The following is a description of a gene set: Abnormality of the curvature of the cornea studied in species Homo sapiens Human Gene Set: HP_ABNORMALITY_OF_THE_CURVATURE_OF_THE_CORNEA, and this is the list of marker genes: BAP1, BRIP1, MYT1L, COL9A1, SDCCAG8, SLC4A11 (solute carrier family 4 member 11), BEST1, YY1, FANCC, RNF113A, FANCF, LZTFL1, KERA, LRAT, DSE, BBS10, AGBL5, SLC39A8, POGZ, UBE2T, SLC7A14, ZBTB7A, KCNV2, ARCN1, SNRNP200, ARID1B, CAPRIN1, GATAD2B, PALB2, AHI1, COL9A3, RD3, FANCM, GRHL2, SCAPER, EIF4H, NIPBL, DYRK1A, GDF6 (growth differentiation factor 6), RP1 (NCBI Gene Id 6101), TEAD1, CNGA3, KIF11, METTL27, AARS1, BRCA2, CCDC28B, BBIP1, MAD2L2, GTF2H5, KIZ, AIPL1, CERKL, APC2, TTC8, EYS, ADNP, ANTXR1, MKS1, TCEAL1, TBC1D2B, USH2A, BBS9, SLX4, NSD1, ITPR1, NEK2, RFC2, DPAGT1, ARSG, PIEZO2, HRAS, KAT6A, CEP78, EFEMP1, RPGR, SMARCAL1, AP1B1, MYO1H, PRCD, MERTK, GPR143, TOPORS, CNGB1, NOG, HARS1, WAC, MAG, FBXW7, ZNF513, ARL6, KLHL7, NMNAT1, PRPF31, INTS11, PIGQ, REEP6 (NCBI Gene Id 92840), PPP1R12A, ERI1, CFAP418, SMG8, SLC38A8, NR2E3, PDZD8, GRIA1, ARL3, IFT172, PDE6A, PLOD1, SLC2A10, PCARE, GLRB, EDEM3, MAPK8IP3, GUCA1B, WDPCP, STX1A, COL1A2, IFT74, TCF4, ROM1, ARHGEF2, MAN2B1 (mannosidase alpha class 2B member 1), RNU4ATAC, SETBP1, ROBO3, MBTPS2, GNB5, CRB1, CHST14, TUB, USP45, GTF2IRD2, LIMK1, RNU4-2, TNPO2, CLDN16, PRMT7, CRELD1, ZFX, RPGRIP1, CLDN11, CC2D2A, TGFB2, MPLKIP, KRAS, PRPF4, GUCY2D, STXBP1, MAK (male germ cell associated kinase), NRAS, CARS1, DHDDS, KMT2B, RP9, ARPC4, ZEB2, IFT88, TFE3, DNAJC21, PIK3R1, ARL2BP, P4HTM, ZNF408, IMPG1, ALDH3A2, FBN1, PAX2, SCUBE3, OTUD5, ARHGEF18, KDM5B, FANCE, UBAP2L, FIBP, IMPG2, IFT27, CLDN19, ASH1L, ELN, BUD23, CAMTA1, LMBRD2, SAG, RGR, RP1L1, UBE3B, FANCD2, BBS5, CRX, PROM1, ZMIZ1, CHMP1A, PDE6G, KIAA1549 (KIAA1549), PITX2, ZNF469 (zinc finger protein 469), CCDC47, FANCI, VSX1, TRIM32 (NCBI Gene Id 3971), OFD1, GTF2E2, IMPDH1, TULP1, TUBA3D, IQCB1, SEMA4A, CACNA1F, RERE, PACS2, PRPH2, NEUROD2, BBS1, COL9A2, FANCG, BBS2, ERCC4, TBC1D7, CEP19, LMX1B, BLOC1S3, CHRDL1, PBX1, BBS12, NCF1, PRPF6, HK1, BBS7, ANKRD11, RHOA, RAD51, LIG4, ERCC3, AHDC1, RPE65, GTF2IRD1 (GTF2I repeat domain containing 1), GNPTAB, GALNT2, AHR, BRCA1, RFWD3, PRDM5, TARS1, CAMSAP1, OVOL2, TBL2, EMC1 (ER membrane protein complex subunit 1), KCNJ13, FAM161A, GTF2I, SPATA7, RDH12, EBF3, COL8A2, KIDINS220, PCYT1A, FANCA, H1-4, NPHP1, GLI3, RLBP1, HDAC4, POLR3GL, TRIM37, BAZ1B, BBS4, ZEB1, EXOSC5, TGFBI, TMEM270, MIR184, ABCA4, RAD51C, HGSNAT, FSCN2, BMP4, PPP2R5D, INTS1, RHO, NRL, COL17A1, XRCC2, RP2, CHST6, POMGNT1, SLC25A24, IDH3A, VARS1, PIGT, PRPF3, AP3D1, DNAJC30, MARK3, HGD, FANCB, VPS37D, CEP290, COL4A1, TUBB4B, FLNA, CLIP2, DHX38, RBP3, PDE6B, CA4, MKKS, SETD5, RECQL4, DPYD, CDHR1, TBCE, COL3A1, NR2F1, RNF2, CAMK2B (calcium/calmodulin dependent protein kinase II beta), MBD5, SCLT1, CHD4, C1QBP, LCA5, IFT140, FANCL, CHD3, FKBP6, IDH3B, PRPF8, SHOC2, RAP1B, CLRN1, ERCC2, PRKAR1B, CNGA1 (cyclic nucleotide gated channel subunit alpha 1), MAP3K7, MT-TS2, NFIX, USP9X (ubiquitin specific peptidase 9 X-linked), AEBP1, TYR